The following is a description of a gene set: Genes predicted to be targets of miRBase v22 microRNA hsa-miR-561-5p in miRDB v6.0 with MirTarget v4 prediction scores > 80 (high confidence targets). species: Homo sapiens Human Gene Set: MIR561_5P from publication Chen Y, Wang X (PMID 31504780), and this is the list of marker genes: PDS5A, ALX4, RCOR3, N4BP2L2, VPS37C (NCBI Gene Id 55048), NPM3, BRAF, SLC1A2, RDH10, GSPT1, SLC5A1, MAGEE1, SESN3, CCDC88A, DMRTA1, ERI2, RBBP4 (RB binding protein 4, chromatin remodeling factor), ADGRA3, SIGLEC5, ZNF384, PLXNA4, AHCYL2, MMGT1, RASSF10, ELAVL4, MDGA2, APLF, EHBP1, ARFGEF2, MAPK6, PLIN5, ELOVL7, WDR76, ZNF449, EEA1, UNC5C, SDF4, TSC22D1, SMAP1, MAPK10, ABHD13, BCL11B, ACTG1, PDK3, NDUFA9 (NCBI Gene Id 4721), OPA1, SH3RF1, GTF2H5, GPATCH2, COL1A1 (NCBI Gene Id 4970), MDM4, DENND5A, SLIT2, ZNF236 (zinc finger protein 236), SLX4IP, NMNAT2, ZNF708, STK35, GOLGA8H, GLO1, MED1, FKBP1A, GPR88, RALA, ZNF480, NTRK2, GABRA1, ERCC6, WNK3, PPM1E, PRRC1, CUL4B, LTB4R, ZCCHC2, GLIPR1, TENM1, CARNMT1, MMUT, NUFIP2, CFAP65, CD300LD-AS1, EIF3J, MAGEB1, PCNX1, TMEM167B, TMEM123, TRPM3, DDX21, SLAIN2, USF3, RAC1, ASH1L, POGLUT1, KDM7A, YOD1, DYNLRB1, NID1, BNIP1, PDE7A, INSIG1, DDX4, MICU3, PAX7, ZNF461, SKIL, GOLGA8T, MINDY2, PAPLN, EFCAB13, ARHGAP5, HMGB1, GOLGA8M, HEXIM1, ALDH5A1, REEP3 (NCBI Gene Id 221035), OSBPL8, ZNF737, RANBP3L, DOK6, NME6, KLK7, SORCS2, SIRPB1, STK4, SLC4A11, ZXDB, CKAP2, SPX, DIP2B, TRPC5, ZNF99, REV3L, GATAD2B, RERE, TMF1, EIF4G2, KCNN3, ZNF804A, KIF5B, HMBOX1, PAXBP1, WWC3, PLXNA2, TPH1, ZNF655, NAP1L1, FZD10, PLXNC1, SELENOS, ATP2C1, DESI1